Given this list of marker genes IPCEF1, SCARB1, ACSS2, CD55, PRICKLE2, TRMT13, CNKSR2 (NCBI Gene Id 22866), GAL3ST4, HIVEP1, TMEM272, PRKCA, ACER1, CLCN5, MANSC1, ADGRA3, SLC25A37, TTN (NCBI Gene Id 7847), DDR1, BEND5, DEPDC7, TMEM41B, MAML2 (NCBI Gene Id 84441), TET3, ZNF275, UBE2B, ALS2CL, USP11, ZNF496, KLHL2, OBSCN-AS1, MYB, LINC01089, NPAS2, PDCD4-AS1, ZNF563, PIGL, KLHL13, TCF7, ZNF439, DBH-AS1, NBEA, MPP1, LEF1-AS1, ZNF138, RNF157-AS1, GRAP, APBA2, GGT7, CDCA7L, EFNA1, LAMA5, ZNF253, SLC12A6, ZNF43, RAB3GAP1, AFF3, FCGRT, EEF1G, CRTC3, PCSK5, ROBO3, LEF1, CHI3L2, CD8B, RBM27, CHMP7, BNIP3L, TGFBR2, EDAR, ELFN2, MLLT3, FCMR (Fc mu receptor), SFMBT2, IGF1R, TMEM198B, LINC03006, NDFIP1, PDE9A, UBE2E2, TAF4B, FAM117B, ZBTB18, ZNF516, PCED1B, PADI4, TOM1L2, NOG, NEMP1, H1-0, PDE7A, RBM11, SERTAD2, PDE3B, SNHG32, AK5, MTHFD2L, GP5, KLF7, TRABD2A, KRT18, CAMK4, PHGDH, SNPH, LTBP3, IL6ST, ARMCX2, SNHG7, PIK3IP1, CCDC3, KLHDC1, LZTS3, SREBF1, DCAF16, CEP41, SLC16A10, TUG1, SNN, PDE7B, AGMAT, VNN2, CERS6, ME3, SDHAP2, FLNB, FOXP1, RGS10, PLAC8, SPTBN1, TOP1MT, TBL1X, CCDC110, ZNF506, TTC28, GPRASP1, PITPNM2, SLC8B1, DNHD1, TMEM245, PLAG1, RPS5, SATB1, ZNF763, ATM, AARS1, KLHL3, PRRT1, AIF1, ZNF708, KYAT1, USP44, PIK3CD, NUDT12, RIN3, TECPR1, ENOSF1, RAB43 (NCBI Gene Id 339122), NFKBIZ, NUCB2, TBC1D32, IGIP, EPHA1, DNMT3A, ITGA6, LRRN3, KBTBD11, LINC01550, DENND2D, PDK1 (pyruvate dehydrogenase kinase 1), ABLIM1, DACT1, NIPAL3, BACH2, AMN1, MMAB, PRXL2A, MGA, KPNA5, CENPV, CD7 (CD7 molecule), ACTN1, SCML2, SERTM1, SETD1B, AEBP1, TPCN1, HIPK2, FBXL12, RAPGEF6, MEF2A, CRLF3, SFXN2, LAGE3, CHST2, MTMR9LP, ZNF510, ZNF780B, TARBP1, PLXDC1, here is a description of the gene set: from publication Abbas AR, Wolslegel K, Seshasayee D, Modrusan Z, Clark HF (PMID 19568420) Genes up-regulated in comparison of naive T cells versus effector memory T cells. Human Gene Set: GSE11057_NAIVE_VS_EFF_MEMORY_CD4_TCELL_UP Microarray deconvolution is a technique for quantifying the relative abundance of constituent cells in a mixture based on that mixture's microarray signature and the signatures of the purified constituents. It has been applied to yeast and other systems but not to blood samples. Here we test the ability of this technique to determine the fractions of subsets of memory T cells in peripheral blood mononuclear cell (PBMC) samples. species: Homo sapiens